Given this list of marker genes Dcn, Eef1a1, S100a6, Klf13, Ybx1 (Y box protein 1), Tmem160, Rpl13a, Tle5, Oaz1, Rhoc, Chmp2a, Igtp, Icam2, Rpsa, Smagp, Stmn2, Ptms, Arhgdia, Ier3, Junb, Snrpc, Cd9, Ier2, Cldn5, Clu, Ppp1r15a, Rpl3, Fam110d, Bsg, Sertad1, H2-D1, Ckb, Meox1, H2-Aa, Bri3, Ldhb, Rps3a1, Rplp0, Map1lc3a, Cd74, Laptm4a, Mllt6 (NCBI Gene Id 246198), Pfn1, Ctsd, Ccn1, Hmg20b, Lyz2, H2-Q6, Bnip3, Gnb1, Mgst1, Rpl6, Skil, Fos, Ubb-ps, Rpl4, Cfl1, Bcl10, Rnaset2b, Aldh2, Aldoa, Tex261, Ptma, Nr4a1, Mtarc2, Mgll, Hexb (hexosaminidase B), Atf3, H2-K1, Tmed9, Slc26a10, Jund, Arpc1b, Spag7, Apoe, Dpysl2, Tcf15, Mgp, Anxa2, Msx1, H3f3b, Sdc4, Tppp3, Capg, Trf, H2-Eb1, Gltp, Lrrc8a, Rpl13, Ecm1, Tagln2, Gsn, P2ry12 (purinergic receptor P2Y, G-protein coupled 12), Adrm1, Gpr34, Ldha, Pcp4l1, Spr, Kdm6b, Ccdc85b, Pkm, Clic1, Gstm2, Lgmn, Ece1, Eif5a, C1qb, Dusp1, Srsf5, Cltb, Igfbp7, Smco4, Tmsb10, Drap1, Calm2, Prr13 (NCBI Gene Id 72100), Klf2, H2-Ab1, Rps3, Eif3f, Gpx4, Plpp1, Abi3, Gata3, Vim, Tgtp2, Smad7, Egfl7, Ube2v1, Lysmd2, Tgfb1i1, Ftl1, here is a description of the gene set: studied in species Mus musculus Mouse Gene Set: TABULA_MURIS_SENIS_HEART_ENDOTHELIAL_CELL_OF_CORONARY_ARTERY_AGEING from publication Tabula Muris Consortium (PMID 32669714)